Given this list of marker genes PDZD11, FKBP1B, ATP10B, ATP8B4, ATP1A1, CLIC2, ATP9B, ANO2, ATP6V0B, CASQ2, ATP2B1, TRPM3, ATP8B2, TRPC4, ATP10D, RYR3, WNK4, SLC9B1, UNC79, TRPC5, RIPK3, NEDD4L, SLN, CLCNKA, SLC9C1, ATP6V0D2, FXYD2, RIPK1, ATP8A1, ANO9, ANO8, CUTC, ATP9A, FXYD4 (NCBI Gene Id 53828), RAF1, ATP13A2, TRPV1, BEST2, ATP1B2, TRPM1, ATP2A1, ATP2A3, ASPH (aspartate beta-hydroxylase), SLC9C2, ATP2C1, CLCA1, TRPM6, ATP10A, ATP6AP1, CASQ1, BEST3, TRPC4AP, SLC9B2 (solute carrier family 9 member B2), ATP8B1, TRPA1, SCNN1D, TRPM2, CLCN6, RYR1, FXYD3, CLCA4, ATP2B2, TCIRG1, FXYD1, UBC, PLN, ATP8A2, TTYH2, MCOLN1, TRPV4, ATP2C2, FXYD6, MCOLN3, ATP1B3, ATP6V1G2, ATP6V0A2, TPCN2, ATP6V0E2, FXYD7, ATP6V1C1, ATP1A4, ATP6V0A1, TPCN1, ATP6V1E2, CLCN3, NALCN, TRPV6, SCNN1G, ATP6V0A4, ATP7B, ATP1A3, CAMK2B, ANO6, CAMK2D, TTYH1, ATP6V1B2, SGK2, SRI, ATP11B, CLCNKB, SGK3, BEST4, ANO4, TRPM4, ATP11C, ATP6V1D, CAMK2G, ATP4A, BSND, ASIC3, MCOLN2, ASIC4, BEST1, ATP6V1G3, ATP11A, CALM1 (NCBI Gene Id 801), CAMK2A, CLCN1, TRPC6, RPS27A, CLCN2, ASIC1, UBA52, ATP2B3, ATP8B3, TRPV5, ASIC2, SGK1, ATP2A2, TRPM7, ANO7, CLCN4, SLC17A3, MLKL, UBB, WNK1, STOML3, ATP6V0C, ATP6V1A, ATP6V1B1, TSC22D3, SCNN1B, WWP1, TRDN, WNK2, TRPM8, TRPC7, ATP6V1E1, ATP4B, ATP12A, TRPC1, UNC80, TRPM5, SCNN1A, RYR2, TRPV3, ANO10, TTYH3, ANO1, STOM, ATP13A5, ATP6V1C2, ANO3, ATP1B1, CLCN5, ANO5, ATP6V0E1, ATP7A, ATP6V1F, WNK3, ATP6V0D1, ATP6V1G1, CLCN7, ATP13A4, ATP1A2, ASIC5, TRPC3, ATP6V1H, ATP2B4, TRPV2, ATP13A1, OSTM1, CLCA2, here is a description of the gene set: Ion channel transport Human Gene Set: REACTOME_ION_CHANNEL_TRANSPORT species: Homo sapiens